Given this list of marker genes Hspa1a, Dusp1, Rgs1, Hspa1b, Fos (NCBI Gene Id 14281), here is a description of the gene set: Mouse Gene Set: CUI_MIGDC_TWEAK_RESPONSE_DN studied in species Mus musculus Genes negatively differentially expressed in cell type: MigDC (migratory dendritic cell) upon treatment with cytokine: TWEAK in mouse lymph nodes in vivo. Cytokines mediate cell-cell communication in the immune system and represent important therapeutic targets. A myriad of studies have highlighted their central role in immune function, yet we lack a global view of the cellular responses of each immune cell type to each cytokine. To address this gap, the authors created the Immune Dictionary, a compendium of single-cell transcriptomic profiles of more than 17 immune cell types in response to each of 86 cytokines (>1,400 cytokine-cell type combinations) in mouse lymph nodes in vivo. A cytokine-centric view of the dictionary revealed that most cytokines induce highly cell-type-specific responses. For example, the inflammatory cytokine interleukin-1β induces distinct gene programmes in almost every cell type. A cell-type-centric view of the dictionary identified more than 66 cytokine-driven cellular polarization states across immune cell types, including previously uncharacterized states such as an interleukin-18-induced polyfunctional natural killer cell state. from publication Cui A, Huang T, Li S, Ma A, Pérez JL, Sander C, Keskin DB, Wu CJ, Fraenkel E, Hacohen N (PMID 38057668)